Given this list of marker genes AQP6, AQP8, AQP11, AQP5, AQP4, AQP2, AQP7, AQP1 (NCBI Gene Id 358), AQP3, AQP9, AQP10, AQP12A, MIP, here is a description of the gene set: species: Homo sapiens Human Gene Set: REACTOME_PASSIVE_TRANSPORT_BY_AQUAPORINS Passive transport by Aquaporins